Given this list of marker genes Ncor1, Tox, Fut7, Foxp3, Tgfb1, Klhl25, Ifng, Gimap5, Il2rg, Pla2g2d, Gimap3 (NCBI Gene Id 83408), Kcnk18, H2-Ea, here is a description of the gene set: Mouse Gene Set: GOBP_CD4_POSITIVE_CD25_POSITIVE_ALPHA_BETA_REGULATORY_T_CELL_DIFFERENTIATION The process in which a precursor cell type acquires the specialized features of a CD4-positive, CD25-positive, alpha-beta regulatory T cell. studied in species Mus musculus